The following is a description of a gene set: studied in species Mus musculus Any process that stops, prevents, or reduces the frequency, rate or extent of cell death by apoptotic process in neurons. Mouse Gene Set: GOBP_NEGATIVE_REGULATION_OF_NEURON_APOPTOTIC_PROCESS, and this is the list of marker genes: Nrp1, Dnajc5, Agtr1a, Gba1, Bag1, Rock1, Ppargc1a, Cblc, Chl1, Angpt1, Gclm, Crhr1, Hif1a, Rnu12, Il10, En1, Xrcc2, Vegfb (NCBI Gene Id 22340), Pcdhgc4, Birc5, Msh2, Apoe, Fbxo7, Map2k4, Hsp90ab1, Sema3e, Kdm2b, Itsn1, Foxb1, Unc5b, Sod1, Vegfa, C5ar1, Optn, Gdnf, Draxin, Grk1 (G protein-coupled receptor kinase 1), Slc25a27, Grina, Nr4a3 (nuclear receptor subfamily 4, group A, member 3), Barhl1, Bhlhb9, Thap11, Mt3, Plxnd1, Xrcc4, Gpi1, Esr2, Sirt1, Pcp4, Pcdhgc3, Nfix, Braf, Fmr1, Atp7a, Nr4a2, Cd2ap, Kif14, Nmnat1, Vstm2l, Cntf, Trp73, Aars1, Ppt1, Fgf2, Clcf1, Adam8, Tox3, Ntf3, Wnt1, Ntf5, Tmbim1, Pink1, Erbb3, Mfsd8, Npm1, Tmbim4, Oxr1, Lonrf2, Pou4f1, Retreg1, Pin1, Kras (NCBI Gene Id 232521), Agap2, Ube2v2, Rad21, Hipk2 (NCBI Gene Id 68602), Pycr1, Ucp2, Atg7, Fzd1, Hspd1 (NCBI Gene Id 15510), Tgfb3 (NCBI Gene Id 21809), Epor, Grik2, Il6, Hmox1, Sncb, Nes, Ccl12, Ctnnb1, Hras, Pla2g3, Bcl2, Tfap2b, Cpeb4, Gclc, Adora2a, Mt1, Gdf5, Esr1, Hyou1 (NCBI Gene Id 58204), Cx3cr1, Bcl2l1, Cx3cl1, Star, Bax, Ntrk2, Stxbp1, Gbe1, Cacna1a, Ngfr, Map3k12, Lgmn, Nono, Psen1, Vps54, Grn, Tfap2a, Set, Prkci, Sod2, Ccnd1, Mag, Amigo2, Pcdhgc5, Bdnf, Adnp, Hsph1, Faim2, Grin1, Atf4, Cln3, Prdx2, Stambp, Fzd9, Ptk2b, Lrp1, Cited1, Il27ra, Syngap1, F2r, Fxn, Cln8, Prdx3 (NCBI Gene Id 11757), Xiap, Clu, Gfral, Nfatc4, Arrb1, Ambra1, Nos1, Pik3ca, Mdk, Pdpk1, Nppc, Ndnf, Arrb2, Fyn, Nefl, Ucn, Fgf8, Kdr, Mtnr1b, Snca, Mef2c, Coro1a, Prkn, Six1, Alkbh1, Agtr2, Bok, Rhoa, Ntrk1, Slc1a1 (NCBI Gene Id 319379), Epha4, Grm7, Agtr1b, Six4, Fgf20, Prkcg, Foxq1, Nrbp2, Jak2, Mecp2, Lig4, Cebpb, Pin1rt1, Ptprz1, Mdga2, Wfs1, Glp1r, Crlf1, Zpr1, Bbs10, Lcn2, Isl1, Ilk, Smo, Btg2, Park7, Sct, Hdgf, Dlx1, Tfap2d, Tyro3, Ngf, En2, Jun, Snx6, Il6st, Axl, Cntfr, Tert, Agt